The following is a description of a gene set: electronically inferred by orthology from the curated human pathway part of: Downstream signaling of activated FGFR2 species: Mus musculus This event has been computationally inferred from an event that has been demonstrated in another species.<p>The inference is based on the homology mapping from PANTHER. Briefly, reactions for which all involved PhysicalEntities (in input, output and catalyst) have a mapped orthologue/paralogue (for complexes at least 75% of components must have a mapping) are inferred to the other species. Reactome Pathway: FRS-mediated FGFR2 signaling, and this is the list of marker genes: Hras (NCBI Gene Id 15461), Fgf22, Fgf1, Fgf20, Frs2, Fgf16, Fgf17, Fgf6, Fgf7, Fgf10, Fgf23, Fgf2, Fgf8, Fgf5, Fgf4, Grb2